Given this list of marker genes C1orf43, GFOD2, COL5A1, HEXA, GNRHR2, ASMTL, ITM2C, RAB3IL1 (NCBI Gene Id 5866), KCNQ2, GET4 (guided entry of tail-anchored proteins factor 4), NUDCD1, CCDC34, MORC2 (NCBI Gene Id 22880), TLN2, RPS24P13, GNPTG, PCLAF, ADPRS, PHC2-AS1, DNAJB5, GTF2H5, LINS1, WDPCP, RBM39, ANKRD20A8P, PHTF2, CRYAB, LINC00475, HOXB9, SLC35F6, ARSA, SLC2A13, PHC2, UPP1, CROCC2, VAC14, CNOT10, RBM4, TVP23B, WASHC2A, TEF, ABHD14B, HEXIM1, ZNF461, PIP4K2C, PRDX3, IMP4, TSR3, OR1X5P, SPRED1, ZNF182, JPH1 (junctophilin 1), ZNF542P, MOB1A, COX16, TNPO3P1, ENY2, UGGT2, MYO1B, BYSL, COMMD4, CTSC, ZNF470, MGA, ZNF84-DT, SLEAR, C19orf12, RNU6-657P, AOPEP, ALG10B, ENSG00000212551, LDLRAP1, DMTF1, HCG14, SERPINI1, NICOL1, NELFA, PCDHA7, CFAP61, SPAG7, ZNF286B, ARHGEF12, SULT1A2, TPRKB, SPANXB1, CARD8, BAG6, MNAT1, LINC01010, CALCRL, KMT2C, TNPO2, RPL7P12, PLA2G4C, BORCS7-ASMT, FRA10AC1 (FRA10A associated CGG repeat 1), SPG11, NEDD4L, VTCN1 (NCBI Gene Id 79679), STOX1, RN7SL525P, KDM4C, TNPO1P2, ADCYAP1R1, WFDC21P, LINC02724, ZNF57, PNKP (polynucleotide kinase 3'-phosphatase), NDUFAF1, ERI2, PHF19, DPYSL4, HFM1, NBPF12, LINC00937, GLA, MIR100HG, MIR4434, SH3GL2, NSMCE2, IPO11, MCCC1, QRFPR, NEK1, SPACA5, NAPG, ZNF84, SLC25A32, CAPN10-DT, RGMB, CAPG, NDUFAF2, UBR1, RNVU1-14, DNAJC25, USP19 (NCBI Gene Id 10869), BNC2, EPN1, DNAJA1, TNK2, CLCN3, PAK1, LSM2, ZNF7, LINC01976, SNAP47, AIDA, HSD17B12, PDXDC1, CLASRP, RPS23P9, PLA2G4E, WDR62, DENND6A-DT, RC3H2, EPCAM-DT (NCBI Gene Id 107985882), ZNF610, ANKRD11, ATAD3A, MED23, TNS1, WDR87BP, NEMP1, NSFL1C, CLN3, DPY19L2P1, SREBF1, MED20, TGFB1I1, ARHGEF2, MTCO3P12, INTS1, MCOLN1, ZNF680, FRMD4B, SLC35E2B, HMGB1, SHISAL2B, TMCO1, MYO18B-AS1, CCAR2, SMG7-AS1, PIP4P1, TCP10L2, ABHD14A-ACY1, ADRA1A (adrenoceptor alpha 1A), DNAJC12, MIR1302-3, MRPS2, YKT6, CEP162, HNRNPH2, LMAN2, CCDC32, RPS27P7, CCDC59, GARS1, PC, TMEM60, COMMD9, HEXIM2, ZSCAN26, SAE1, REXO5, GOLGA3, ZNF165, NCAPG, PIAS4, WDR12, PTPRD, SULT2B1, EPG5, NOSIP, WWP1P1, MDH1B, PNRC2, RABGGTB, MED28, MYMK, ZNF551 (zinc finger protein 551), PRPF31, ESD, LINC02846, EMC2, ALG1, DNAJC25-GNG10 (DNAJC25-GNG10 readthrough), SF3A3, LINC01508, LRP1B, ISLR2, PHF3, ORAI1, AFTPH-DT, PARP3, FAM230G, BNIP2, SLC31A2, UBAP1, NUDT16-DT, RNA5SP283, STK3, SIMC1, MIR3148, UVRAG, NOSTRIN (NCBI Gene Id 115677), TACO1, ACTR3, SLX4IP, TBC1D5, MIOX, KIAA0513, CCDC144NL-AS1, ACTMAP, CIB2, RNVU1-28, HDAC4-AS1, TMEM248, PRKCG, STYXL1, ANKRD36C, STON2, TUBA4A, BZW1 (basic leucine zipper and W2 domains 1), CTNNA1-AS1, EHD4-AS1, ZNF83, PDIA5, LTBP4, JMJD4, ENSG00000250915, SYNCRIP (NCBI Gene Id 10492), NTHL1, FAM21EP, TFPT, NDUFB7 (NCBI Gene Id 4713), TBRG4, IPO7, CERNA1, RBBP5, DVL2, ZBED6, BLOC1S1, C19orf81, DCTN4, SATB1, SPG7, EML2, C17orf75, VPS4B, ELK1, MTHFR, ATP4A, STUM, SCN8A, GABRB3, CTNNA1, TNIP2, SLC33A1, PRKRIP1, CTPS2, CHAF1A, ENSG00000275173, BROX, CENPA, THUMPD1, SLC11A2, NHSL1, VPS26A, PLCXD1, SNRPD1, LINC01089, LINC01893 (long intergenic non-protein coding RNA 1893), TRIP6, TRAJ23, NR2F2, PDCD6, LINC01719, NUDT11, KAT5, TRIM36, HOXB5, KCNQ1, IDS, IBA57-DT, SVOP, UBE2E1 (ubiquitin conjugating enzyme E2 E1), BTBD10, RNU1-6P (NCBI Gene Id 106480152), BTNL12P, RPH3AL, UBAP2L, GUSBP2, FKBP8, DDX11L5, RNF43 (ring finger protein 43), PGAM5, UBXN2B, CCDC87, APBB2, MAP9, GSTA4, TPT1-AS1, ZC3H14, MYO5A, TCF25, RNVU1-15, LINC01392, DRC3, LBR, STX4, HINFP, CLCN6, PVALEF, RBM15-AS1 (NCBI Gene Id 440600), CD7, PEX11A, TM7SF3 (transmembrane 7 superfamily member 3), CCNYL1, VASP, ATAD2, SACM1L, NAB2, MIR4449, CALM1, EFCAB10, RAB12, SLC38A2, EXD2, SDHB, CCNC, EXOC4, GEN1, WDR59, ANKRD36, GDAP1, TOM1L2, CDK11A, ZNF233, RHOF, GULP1, PRRG2, LMF1, PCM1, SIK2, GRB2, B4GALT6, SPNS1, MDH2, BRD1, METTL5, ZFP30, ZNF321P (NCBI Gene Id 94100), ABHD13, BIN1, SLC6A1, CARMAL, RPL36P5, DMXL1-DT, METTL25, ENSG00000247416, LINC02533, TLL2, RDUR, ERCC8, DMTF1-AS1, FOXK2, CD200R1, FLJ30679, TRAM1L1, MRPS31P5, ANKRD20A5P, ENSG00000260288, FANCC, DENND6A, PCYT2, FRY, RNU1-1, ENSG00000293341, BORCS7, AFTPH, IBA57 (NCBI Gene Id 200205), CISD2, EMC10, MECP2 (NCBI Gene Id 8274), RELB, EME1, FDXR, FAM181B, IDH3A, PRORSD1P, ZFP69B, EPCAM, IL18R1, PRPF40B, JUP, TCAF1, NDUFB5, PIERCE1, RAG1, DANCR, PARP2, TRIB2, PLSCR1, SMG7, RBM4B, CRLS1, FCRL5, LRRC37A3, FASTKD2, SERAC1, HCG20, HNF4G, L3MBTL1, PDCD2, SPECC1P2, PLEKHM3, FBXO44, MTHFD2, RTF1, ART3, TTC24, MRPL27, NCOR2, LINC02598, GBA1, FAM98B, MAML3, ADGRB2, ZZEF1, FLRT3, IQSEC1, ZNF286A, ABCC12, TARS3, DPY19L4, EIF4H, LY6K (NCBI Gene Id 54742), EFCAB7, LINC01116, TOP3B, CACNG7 (calcium voltage-gated channel auxiliary subunit gamma 7), ZNF528, RPPH1, KMT2A, CARF, TNFAIP3, DIP2A, ZNF143, NEXN, ZNF292, FABP5P3, BPHL (NCBI Gene Id 83355), ACBD7, SOX9-AS1, HEATR3-AS1 (HEATR3 antisense RNA 1), C22orf15, BVES-AS1, DDX11L10, JPX, SEMA6A, P2RX6, MEMO1, RRN3, HTR5A, CEP68, EPHA3, RNF181, ADAP2, WDR93, DMAP1, LRRN2, TRIP4, MSH3, DMAC2L, HMGXB3, DUSP26, PCBP4, ZNF136, INTS5, RPS6KB1, MAFA, SYNE2, APP, GNAL, BAIAP2, USPL1, MBOAT7, PEX11B, RABEPK, TSC2, CIT, ITGB3BP, MAP3K5, DMXL1, GALNT16-AS1, ZNF789, SERF2, PTDSS2, COX20, CASP9, PCSK6-AS1, ADGRL1, SFXN5, ZNF8, AGTRAP, UBE2D3, FUT10 (NCBI Gene Id 84750), KRTAP9-6, RNA5SP146, TMX2, BPIFB1, LAMP1, TP53I3, CHST12, ZC3H11A, MMEL1, CD96, ZNF343, FAM111A, CARS2, ARHGAP22, IDO1, PDK3, XKR6, ALDH3A2, LINC01749, TBL3, PSMF1, SNRPA, NBN, ZNF582-DT, RRP9 (ribosomal RNA processing 9, U3 small nucleolar RNA binding protein), WDR18, ITGB5, C19orf47, CCS, VAMP7, MARCHF8, NR4A1, RNU6-1137P, BAZ2A, ATAD2B, GTF2B, IGLV7-46, LRRC37A5P, ZFAND1, POLR2J3, ENSG00000260209, ZSCAN5A, KANSL1, MINDY3, HSD11B1L, ERCC1, OBSCN-AS1, TMEM167B-DT, TRAF6, HGFAC, ZNF148, SAP18, FAM111A-DT, LINC02366, ZBED5-AS1, PDXK, LUM, BAALC-AS1, CERS6-AS1, CLDN14, HEMK1, C2orf69P2, PICALM, LINC01703, CLSTN1, HSPB2, CCDC115, HEXIM2-AS1, B3GNTL1, PHAF1, GTF2IRD1P1, ZFYVE26, CLPB, HDAC4, RUBCNL, C12orf42, CCDC9, OXSR1, CEP78, CRYL1, HNRNPK, FRMD3, TRIM28, MED28-DT, ANKRD24, MED19, COMMD2, TMEM167B, PNPLA6 (patatin like phospholipase domain containing 6), N6AMT1, ZNF875, TSEN34, MIF, EFHB, ZNF286A-TBC1D26, SLC38A2-AS1, SEMA4C, CYB5B, FGD3, SLC35B4, SGSM1, THAP8, CDK20, SLC40A1, IL10RA (interleukin 10 receptor subunit alpha), BAX, RAPGEF2, MIR4277, GARIN5A, ANKRD12, CCDC107, SAMD7, ZNF493, NUDT16, CABLES2, ZNF582, RBM15, ERLIN1, RTRAF, DCDC2, GCAT, ILVBL, YAP1, KLHDC1, NDUFAF6, SPG21, RIMS1, RPL37 (NCBI Gene Id 6167), UQCC6, ATL2, CHMP4C, DCAF13, TNNT1 (troponin T1, slow skeletal type), LINC01596, RAB3GAP2 (RAB3 GTPase activating non-catalytic protein subunit 2), SPOCD1, DNAJC16, RGS17, NUDCD3, RMI1, TRAPPC12, ZNF8-DT, DGKD, HTR3A, CFAP20DC-DT, ZNF512B, ZBED5, PSMA1P1, PLTP, APEH, ENSG00000263011, ZFP64, ZNF564, DCTN6-DT, LMBRD1, DHDH, STX3, PCDHAC1, HSPA1B, VPS33A, LINC00240, CFDP1, CAPN10, RUNX1, LINC01399, RNVU1-4, USP47, GLUD1P2, ENPP3 (NCBI Gene Id 5169), TPRA1, ADNP, RAB5A, TATDN1, B4GALT4, ANKRD50, DNM1L, BZW1-AS1, USP42, NCAM1, SNORA26, WASHC5, TADA1, PKNOX1, KIF17, FNDC3A, MAPK4, RBPJ, SPECC1P1, MRPS31, LINC02384, DHFR, LIG4, WASHC2C, HUS1, PPM1L (protein phosphatase, Mg2+/Mn2+ dependent 1L), DRG2, BPTF, MTF2, RPS17P14, ITGA9-AS1, PDCD6-DT, FAM174A-DT, LAMTOR1, CCNE2, C1QTNF12, ELAPOR2, ARRDC1, WDR6, SPAG17, MKNK2, CYP4A11, PLD3, IGFL4, EXOSC4, TPT1, ADD2, RCBTB2, EEFSEC, PINK1, MCM8-AS1, TEFM, ZNF8-ERVK3-1, FCHO1, ITGA7, HNRNPF, CPSF6 (NCBI Gene Id 11052), LINC02938, ACTR8, CSE1L-DT (NCBI Gene Id 102723483), APTX, SH3BP2, PDCD10, PCBP2, JAKMIP3-AS1, MTHFSD, ENSG00000272008, CCNT1, LATS2, DENND4C, PPP1R3D, RIMOC1, IER5L-AS1, FAM21FP, PRNP, RPUSD3, DNM1P35, AP3D1, RBKS, CEP128, ARFIP1, MRPL38, HLA-DQB1-AS1, CCBE1, PGK2, ABI2, HEXA-AS1, SLC44A1, here is a description of the gene set: from publication Yevshin I, Sharipov R, Kolmykov S, Kondrakhin Y, Kolpakov F (PMID 30445619) Human Gene Set: ZNF528_TARGET_GENES Genes containing one or more binding sites for (ZNF528) in their promoter regions (TSS -1000,+100 bp) as identified by GTRD version 20.06 ChIP-seq harmonization. species: Homo sapiens